Given this list of marker genes MAPK10 (NCBI Gene Id 5602), IRAK1, FOS, TRAF6, MAP2K7, JUN, MAPK8, MAP2K4, MAPK9, IL1RAP, IL1R1, IL1A, IRAK4, MAP3K7, TAB2, TAB1, MYD88, IL1B, TAB3, here is a description of the gene set: Human Gene Set: KEGG_MEDICUS_REFERENCE_IL1_IL1R_JNK_SIGNALING_PATHWAY Pathway Definition from KEGG: IL1 -> IL1R -> MYD88 -> IRAK1/4 -> TRAF6 -> TAB1/2/3 -> TAK1 -> MKK4/7 -> JNK -> AP1 IL1-IL1R-JNK signaling pathway. Pathway ID: N00188. Pathway type: Reference. Pathway class: nt06526 MAPK signaling. studied in species Homo sapiens